Given this list of marker genes RRP8, RPL23, RAB11FIP4, MYBBP1A, TP53, here is a description of the gene set: studied in species Homo sapiens Any process that modulates the frequency, rate or extent of G1 to G0 transition. Human Gene Set: GOBP_REGULATION_OF_G1_TO_G0_TRANSITION